Given this list of marker genes ZDHHC14, LRRK1, TYRO3, SLC38A3, DHDDS, CD22, ABHD18 (NCBI Gene Id 80167), VPS51 (VPS51 subunit of GARP complex), ZNF440, STARD7, DNAJB2, SNRPA, TTBK2, ELP3, TUBB3, IL36G, RPL10, PRKRA (protein activator of interferon induced protein kinase EIF2AK2), STAG1, BLM, UBAC1, SLC66A2, RBM42, HRH1 (histamine receptor H1), RCAN3, TUBGCP4, CXCL2, TTC13, HS3ST1, RDH11 (retinol dehydrogenase 11), CA5B, MYCNOS, ACD, CSNK2A1, EXO5, DDB2, PLPP3 (NCBI Gene Id 8613), DNAJC13, PLEKHB2, WRAP73, POU4F3, CTNNBL1, LRRC8E, ZNF239, ZNF205, TCTA, SPATA2L, PRKAA1, CYBRD1, CSRNP2 (NCBI Gene Id 81566), MUSK, PLD1, FAR2, CLDN10, SGK2 (NCBI Gene Id 51178), GPR12, HAND1, ACTN2, RPN1, THAP7, ATP6V1G2, PORCN, THOC7, KLF13, DUSP13B, SMIM14 (NCBI Gene Id 201895), P4HTM, REXO2, P2RX4, SAV1, CCN5, SLC12A2, YWHAH, MGLL, UCHL5, RIN1, NR3C2, CTSF, LINC00623, DNAJC7, MUS81, MAPK4, PDGFD, BNC2, RPL6, ATP5F1E, CYP26A1, PUM1, NUDT21, ACTR1B, MED9, TRNAU1AP, UBE2C, GLOD4, AOC2, CCL18, ZKSCAN3, SNRNP27, PSMA1, MED13, LSS, ACVR1, GCLM, AKAP8, FAM117A, TRIM28, LAMA5, PEX11B, CFB, SUZ12P1, ASL, AOPEP, HJURP (NCBI Gene Id 55355), TRAF4, SLAMF7 (SLAM family member 7), F12, EIF4G3, GAST, CSF2, SEMA4D, TPST2, COMMD4, KRT2, MFSD13A, SLC41A3, THADA, IL12B, PPP3CB, ARG1, ZNF592, HERC1, LTA4H, C11orf68, WNT11, USP5, ANXA5, MAP3K1, TSR2, PER2, FAM114A1 (family with sequence similarity 114 member A1), AHSG, UBE2K, ACVR2A, IFT46, STARD3, PRSS12, CASP10, DNAJA4, OPRD1, OCEL1, COPB2, YWHAH-AS1, TIMM8B, ATAD2, BTK, CCRL2, RABAC1, KATNIP, SFN, AATF, TPCN1, VAC14, KIF1B, RAB3IL1, NKIRAS2, RPL39, FAM182B, TRMT2B, PTCD1, CEP85, ZNHIT3, MT1G, CBX1, UBE2N (NCBI Gene Id 7334), PCDHGB5, KLF1, SPON1, SNX4, TMED2, DUSP22, H3C6 (H3 clustered histone 6), GSC2, RBM14 (RNA binding motif protein 14), RNF128, LINC00837, FAT1, SUCLG2, SCLY (NCBI Gene Id 51540), PPAN, POP4, DNAJC1 (NCBI Gene Id 95528), OBI1, NFATC2IP, PMS2P4, CD59, BRD3OS, SPECC1L, NGRN, ITPR1, here is a description of the gene set: from publication Billmann-Born S, Till A, Arlt A, Lipinski S, Sina C, Latiano A, Annese V, Häsler R, Kerick M, Manke T, Seegert D, Hanidu A, Schäfer H, van Heel D, Li J, Schreiber S, Rosenstiel P (PMID 21335489) NOD2 is an intracellular receptor for the bacterial cell wall component muramyl dipeptide (MDP) and variants of NOD2 are associated with chronic inflammatory diseases of barrier organs e.g. Crohn disease, asthma and atopic eczema. It is known that activation of NOD2 induces a variety of inflammatory and antibacterial factors. The exact transcriptomal signatures that define the cellular programs downstream of NOD2 activation and the influence of the Crohn-associated variant L1007fsinsC are yet to be defined. To describe the MDP-induced activation program, we analyzed the transcriptomal reactions of isogenic HEK293 cells expressing NOD2wt or NOD2L1007fsinsC to stimulation with MDP. Importantly, a clear loss-of-function could be observed in the cells carrying the Crohn-associated variant L1007fsinsC, while the NOD2wt cells showed differential regulation of growth factors, chemokines and several antagonists of NF-κB, e.g. TNFAIP3 (A20) and IER3. Human Gene Set: GSE22611_NOD2_VS_MUTANT_NOD2_TRANSDUCED_HEK293T_CELL_UP Genes up-regulated in HEK293 cells expressing: wildtype NOD2 versus mutant NOD2. species: Homo sapiens